Given this list of marker genes SFTPB, CSF2RB, SFTPC, PARN, STN1, ATP11A, SFTPA2, DSP, SFTPA1, HLA-DRB1, CSF2RA (NCBI Gene Id 8282), COL3A1, TERC, MUC5B, EIF2AK4, SLC34A2, HLA-DPB1, TERT, ABCA3, NKX2-1, RTEL1, BMPR2, DPP9, FAM13A, ASAH1, here is a description of the gene set: species: Homo sapiens Pulmonary interstitial high-resolution computed tomography abnormality High-resolution computed tomography (HRCT) can distinguish findings that characterize characterize interstitial lung diseases in a way not possible with other modalities. Human Gene Set: HP_PULMONARY_INTERSTITIAL_HIGH_RESOLUTION_COMPUTED_TOMOGRAPHY_ABNORMALITY